The following is a description of a gene set: Human Gene Set: GAVISH_3CA_METAPROGRAM_CD4_T_CELLS_NAIVE_2 from publication Gavish A, Tyler M, Greenwald AC, Hoefflin R, Simkin D, Tschernichovsky R, Galili Darnell N, Somech E, Barbolin C, Antman T, Kovarsky D, Barrett T, Gonzalez Castro LN, Halder D, Chanoch-Myers R, Laffy J, Mints M, Wider A, Tal R, Spitzer A, Hara T, Raitses-Gurevich M, Stossel C, Golan T, Tirosh A, Suvà ML, Puram SV, Tirosh I (PMID 37258682) In this study, an extensive analysis was conducted to define meta-programs (MPs) capturing intra-tumor heterogeneity across a spectrum of tumor types. The approach utilized non-negative matrix factorization (NMF) to analyze each cell type separately within individual tumor samples. This involved the analysis of malignant cells, macrophages, fibroblasts, endothelial cells, epithelial cells, T-cells, and B-cells. NMF was executed with varying parameter values (K=4, 5, 6, 7, 8, 9), thereby generating 39 programs for each cell type per sample. Each NMF program was summarized by the top genes based on NMF coefficients.\nRobust MPs were then delineated for each cell type using a set of stringent criteria, including recurrence within the same tumor, similarity to programs in other tumors, and non-redundancy within a tumor. Subsequently, these robust NMF programs were clustered (per cell type) based on Jaccard similarity, leading to the identification of MPs associated with each cell type.\nTo enhance the quality of the MPs, a refinement steps were undertaken, involving the removal of MPs suspected of reflecting low-quality data (with an overrepresentation of ribosomal proteins or mitochondrial-encoded genes), single-study inclusion, or similarity to miss-annotated cell types. studied in species Homo sapiens Genes upregulated in subsets of cells of a given type within various tumors, and this is the list of marker genes: GIMAP5, APEX1 (apurinic/apyrimidinic endodeoxyribonuclease 1), SELL, PRKCQ-AS1, CD27, CREBRF, LINC00861, TAGAP, RASGRP2, KLRB1, SATB1 (NCBI Gene Id 6304), SH3BP5, TSHZ2, RSL1D1, FHIT, TRAT1, GIMAP2, NOSIP, ITGB1, MCUB, KLF2 (NCBI Gene Id 51713), ALKBH7, IL6ST, TCF7, PRMT2, EPB41L4A-AS1, PIM2, LEF1, C1orf162, MAL, MYC, ICAM2, FOXP1, SNORA50C, GIMAP1 (GTPase, IMAP family member 1), TIMP1, SNHG7, PLAC8, LPAR6, PRKCA, EIF2S3, TRABD2A, SNHG32, SORL1, RIC3, ST13, SMDT1, RIPOR2, TMEM243, CCR7